The following is a description of a gene set: species: Homo sapiens Regulation of innate immune responses to cytosolic DNA Human Gene Set: REACTOME_REGULATION_OF_INNATE_IMMUNE_RESPONSES_TO_CYTOSOLIC_DNA, and this is the list of marker genes: TBK1, NLRP4, DTX4, UBA52, UBB, TRIM56, TRIM21, ZBP1, IRF3, TREX1, UBC, TRIM32, DDX41, RPS27A, STING1